The following is a description of a gene set: The amount of an organic compound in the urine, normalized for urine concentration, is outside the limits of normal. An organic compound is defined here as a chemical compound that contains a carbon-hydrogen or carbon-carbon bond, although some other definitions exist. Examples of organic compounds includes alkanes, alkenes, alkynes, aromatic compounds, alcohols, ketones, aldehydes, carboxylic acids, and esters. Human Gene Set: HP_ABNORMAL_URINARY_ORGANIC_COMPOUND_LEVEL studied in species Homo sapiens Abnormal urinary organic compound level, and this is the list of marker genes: CEL, PIGA, RRM2B, SLC34A1, PRPS1, SLC2A2, MOCS1, ETFDH, PNP, EHHADH, SLC22A12, ETFB, GATA6, KCNJ1, FAH, CYP27A1, BLK, ALAD, HMBS, MT-TN (NCBI Gene Id 4570), APPL1, CLCNKB, GAMT, UMOD, CTNS, SLC16A12, GYS2 (glycogen synthase 2), FAN1, PPOX, ALDOB, PAX4, HNF1B, HNF4A, SLCO2A1, PDX1, SURF1, PBX1, COA8, KCNJ11, CPOX, SLC2A9, OCRL, GCK, PAX2, NDUFAF6, VIPAS39, STAT3, CLDN16, LMNA, KLF11, ETFA, TRMT5, SLC5A1, CLCNKA, CLCN5, GATM, INS (insulin), NSMCE2, HPRT1, HNF1A, BSND, MOCS2, SLC5A2, ABCC8, ATP7B, SLC12A1, NEUROD1